The following is a description of a gene set: studied in species Mus musculus A molecular function exhibited by a protein that is covalently attached (AKA tagged or conjugated) to another molecule (for example a protein or a lipid) where it acts as a marker, recognized by the cellular apparatus to target the tagged protein for some cellular process such as modification, sequestration, transport or degradation. Mouse Gene Set: GOMF_MOLECULAR_TAG_ACTIVITY, and this is the list of marker genes: Uba52, Fau, Rps27a, Ubb, Urm1, Ubl5b, Ubc, Ubl5 (NCBI Gene Id 66177), Isg15, Sumo1, Nedd8, Sumo3, Atg12, Sumo2